Given this list of marker genes VPS35, SNX5, CAV2, DNAJC14, DLG4, PALM, NHERF1, CLIC6 (chloride intracellular channel 6), GNA13, GNAI1, PTGER1, GNAS, ARRB2, PPP1R9B, GNA12 (G protein subunit alpha 12), here is a description of the gene set: Human Gene Set: GOMF_DOPAMINE_RECEPTOR_BINDING Binding to a dopamine receptor. species: Homo sapiens